Given this list of marker genes PPP1CC, FURIN, MAPK3, NEDD8, ARHGEF18, CBL, RHOA, STAT1, CCNT1, RBL1, USP15, HDAC1, CGN, UBE2D1, MYC, CDK8, SMURF2, PARD6A, SMAD7, PARD3, SMURF1, JUNB, SP1, TGFBR2, EP300, ITGB5, UBB, ITGB1, ATP1B4, USP9X, SMAD3, TGFB1, UCHL5, TGIF2, TFDP1, CCNT2, TRIM33, TGIF1, TGFBR3, RNF111 (ring finger protein 111), MTMR4, ITGB6, NEDD4L, UBE2D3, UBE2M, SKIL, ZFYVE9, TFDP2, BAMBI, LTBP1, COL1A2, PPP1CB, SNW1, ITGB3, TGFB2, RPS27A, YBX1, LTBP3, MAPK1, CCNC, E2F4, FKBP1A, PPP1CA, STUB1, TGFBR1 (transforming growth factor beta receptor 1), SERPINE1, ITGB8, LTBP4, PMEPA1 (prostate transmembrane protein, androgen induced 1), CDKN2B, CCNK, PRKCZ, NCOR1 (NCBI Gene Id 9611), WWTR1, SKI, PARP1, E2F5, TGFB3, LTBP2 (NCBI Gene Id 83981), PPM1A, F11R, UBA52, SMAD2, CDK9, NCOR2, UBC, SMAD4, MEN1, ITGA8, XPO1, STRAP, PPP1R15A, FBN1, ITGAV, here is a description of the gene set: species: Homo sapiens The TGF-beta/BMP pathway incorporates several signaling pathways that share most, but not all, components of a central signal transduction engine. The general signaling scheme is rather simple: upon binding of a ligand, an activated plasma membrane receptor complex is formed, which passes on the signal towards the nucleus through a phosphorylated receptor SMAD (R-SMAD). In the nucleus, the activated R-SMAD promotes transcription in complex with a closely related helper molecule termed Co-SMAD (SMAD4). However, this simple linear pathway expands into a network when various regulatory components and mechanisms are taken into account. The signaling pathway includes a great variety of different TGF-beta/BMP superfamily ligands and receptors, several types of the R-SMADs, and functionally critical negative feedback loops. The R-SMAD:Co-SMAD complex can interact with a great number of transcriptional co-activators/co-repressors to regulate positively or negatively effector genes, so that the interpretation of a signal depends on the cell-type and cross talk with other signaling pathways such as Notch, MAPK and Wnt. The pathway plays a number of different biological roles in the control of embryonic and adult cell proliferation and differentiation, and it is implicated in a great number of human diseases.<br>TGF beta (TGFB1) is secreted as a homodimer, and as such it binds to TGF beta receptor II (TGFBR2), inducing its dimerization. Binding of TGF beta enables TGFBR2 to form a stable hetero-tetrameric complex with TGF beta receptor I homodimer (TGFBR1). TGFBR2 acts as a serine/threonine kinase and phosphorylates serine and threonine residues within the short GS domain (glycine-serine rich domain) of TGFBR1.<br>The phosphorylated heterotetrameric TGF beta receptor complex (TGFBR) internalizes into clathrin coated endocytic vesicles where it associates with the endosomal membrane protein SARA. SARA facilitates the recruitment of cytosolic SMAD2 and SMAD3, which act as R-SMADs for TGF beta receptor complex. TGFBR1 phosphorylates recruited SMAD2 and SMAD3, inducing a conformational change that promotes formation of R-SMAD trimers and dissociation of R-SMADs from the TGF beta receptor complex. <br>In the cytosol, phosphorylated SMAD2 and SMAD3 associate with SMAD4 (known as Co-SMAD), forming a heterotrimer which is more stable than the R-SMAD homotrimers. R-SMAD:Co-SMAD heterotrimer translocates to the nucleus where it directly binds DNA and, in cooperation with other transcription factors, regulates expression of genes involved in cell differentiation, in a context-dependent manner. <br>The intracellular level of SMAD2 and SMAD3 is regulated by SMURF ubiquitin ligases, which target R-SMADs for degradation. In addition, nuclear R-SMAD:Co-SMAD heterotrimer stimulates transcription of inhibitory SMADs (I-SMADs), forming a negative feedback loop. I-SMADs bind the phosphorylated TGF beta receptor complexes on caveolin coated vesicles, derived from the lipid rafts, and recruit SMURF ubiquitin ligases to TGF beta receptors, leading to ubiquitination and degradation of TGFBR1. Nuclear R-SMAD:Co-SMAD heterotrimers are targets of nuclear ubiquitin ligases which ubiquitinate SMAD2/3 and SMAD4, causing heterotrimer dissociation, translocation of ubiquitinated SMADs to the cytosol and their proteasome-mediated degradation. For a recent review of TGF-beta receptor signaling, please refer to Kang et al. 2009. part of: Signaling by TGFB family members Reactome Pathway: Signaling by TGF-beta Receptor Complex